The following is a description of a gene set: Catalysis of the reaction: CDP + alcohol = CMP + phosphatidyl alcohol. Human Gene Set: GOMF_CDP_ALCOHOL_PHOSPHATIDYLTRANSFERASE_ACTIVITY species: Homo sapiens, and this is the list of marker genes: CDS1, PGS1, CEPT1, SELENOI, PIGF, CHPT1, CDIPT, PTDSS2